The following is a description of a gene set: Any process that activates or increases the rate or extent of heat generation. studied in species Mus musculus Mouse Gene Set: GOBP_POSITIVE_REGULATION_OF_HEAT_GENERATION, and this is the list of marker genes: Tnf, Tnfsf11, Abat, Slc27a1 (solute carrier family 27 (fatty acid transporter), member 1), Nmu, Apln, Cnr1, Tnfrsf11a, Ccl5, Htr2a, Il1b, Ptgs2, Ptger3 (prostaglandin E receptor 3 (subtype EP3)), Ccr5